The following is a description of a gene set: studied in species Mus musculus Mitotic bipolar spindle assembly begins with spindle microtubule nucleation from the separated spindle pole body, includes spindle elongation during prometaphase, and is complete when all kinetochores are stably attached the spindle, and the spindle assembly checkpoint is satisfied. Mouse Gene Set: GOBP_MITOTIC_SPINDLE_ASSEMBLY, and this is the list of marker genes: Mzt1, Prickle1, Chmp1b, Kifc5b, Map9, Tpx2, Ccdc61, Ccsap, Mybl2, Chmp2a, Kif15, Arhgef10, Zfp207, Hspa1b, Lsm14a, Prc1, Chek2, Khdc3, Smc1a, Chmp6, Chmp5, Cltc, Misp, Kif3b, Racgap1, Kif11, Chmp2b, Chmp7, Cdca8, Kpnb1, Rab11a, Uhrf1, Chmp1b2, Chmp3, Kif23, Clasp1, Kif2a (NCBI Gene Id 319353), Pibf1, Chmp4b (charged multivesicular body protein 4B), Bccip, Hspa1a, Clasp2, Rangrf, Smc3, Golga2, Rcc1, Birc5 (NCBI Gene Id 11799), Plk1, Wrap73, Rhoa, Aaas, Cep192, Ripor2, Cdc20, Stag1, Ofd1, Abraxas2, Ccdc66, Chmp4c, Hnrnpu, Drg1, Snhg15, Incenp, Eml3, Kifc1, Poldip2 (polymerase (DNA-directed), delta interacting protein 2), Nek2, Aurkb, Abraxas1, Flna, Tpr, Cep97 (centrosomal protein 97), Map10, Chmp1a, Vps4b, Kif4, Stag2, Spice1